Given this list of marker genes PEX5, ELOVL4, PEX14, KCNQ2, UNC80, GRIN1, WASHC4, GUF1, NEUROG1, PLEKHG2, GRIN2A, PSAT1, PEX3, RELN, ZNF526, FGF13, LIPT2, PEX2, KCNT2, SLC39A8, CRIPT, MFF, CCDC88A, PIGW, H4C3, KATNB1, COG7, SZT2, PIGA, PIGU, PEX16, DENND5A (NCBI Gene Id 23258), TBCK, STRA6, PEX11B, PEX10, CACNA2D1, QARS1, PRPS1, ARX, PRUNE1, ADK, PEX6, WDR4, ATRX, ISCA2, SETBP1, GLYCTK, NDE1, GOSR2, SLC12A2, ASNS, PEX13, PEX12, PEX1 (peroxisomal biogenesis factor 1), OPA1, NECAP1, SLC9A6, EML1, KCNT1, CACNA2D2, PEX19, RARS2, IREB2, PTPN23, DST, FARS2, ARV1, FDFT1, GLUL, PARS2, AIMP2, PEX26, here is a description of the gene set: Human Gene Set: HP_PROFOUND_GLOBAL_DEVELOPMENTAL_DELAY studied in species Homo sapiens Profound global developmental delay A profound delay in the achievement of motor or mental milestones in the domains of development of a child.